The following is a description of a gene set: The pathogenesis of incipient Alzheimer's disease (AD) has been resistant to analysis because of the complexity of AD and the overlap of its early-stage markers with normal aging. Gene microarrays provide new tools for addressing complexity because they allow overviews of the simultaneous activity of multiple cellular pathways. However, microarray data interpretation is often hindered by low statistical power, high false positives or false negatives, and by uncertain relevance to functional endpoints. Here, we analyzed hippocampal gene expression of nine control and 22 AD subjects of varying severity on 31 separate microarrays. We then tested the correlation of each gene's expression with MiniMental Status Examination (MMSE) and neurofibrillary tangle (NFT) scores across all 31 subjects regardless of diagnosis. These well powered tests revealed a major transcriptional response comprising thousands of genes significantly correlated with AD markers. Several hundred of these genes were also correlated with AD markers across only control and incipient AD subjects (MMSE > 20). Biological process categories associated with incipient AD-correlated genes were identified statistically (ease program) and revealed up-regulation of many transcription factor/signaling genes regulating proliferation and differentiation, including tumor suppressors, oligodendrocyte growth factors, and protein kinase A modulators. In addition, up-regulation of adhesion, apoptosis, lipid metabolism, and initial inflammation processes occurred, and down-regulation of protein folding/metabolism/transport and some energy metabolism and signaling pathways took place. These findings suggest a new model of AD pathogenesis in which a genomically orchestrated up-regulation of tumor suppressor-mediated differentiation and involution processes induces the spread of pathology along myelinated axons. Human Gene Set: BLALOCK_ALZHEIMERS_DISEASE_DN from publication Blalock EM, Geddes JW, Chen KC, Porter NM, Markesbery WR, Landfield PW (PMID 14769913) Genes down-regulated in brain from patients with Alzheimer's disease. species: Homo sapiens, and this is the list of marker genes: CNKSR2, PGK1, TAF9, SNRK, MMD, SCN3B, BECN1, COX4I1, ATP1A2, CYCS, UQCRQ, FUCA1 (alpha-L-fucosidase 1), ADH5, STAMBP, PFN2 (NCBI Gene Id 85837), MCM4, DUSP6, PITPNB, SLC4A3, TSPAN3, ATP5MG, AUH (NCBI Gene Id 549), RPL6, STS, SRSF5, PAK3, SSBP1, UQCRC1, NDUFA7, P4HA1, RTN1, BLZF1, CDK7, USP9Y, FSD1, HDGFL3, TSPOAP1, LRP1B, UQCC1, MAP4K3, KHDRBS1, DDX1, MAN1A1, SSR1, NDUFB2, HYOU1, SPINT2, PTN, LETMD1, CDO1, EPHA4, NELL1, ADORA2B, KCND2, RPRM, STMN3, GPM6A, POLR2J4, TIMM23, PGRMC1, PEX19, CCNL1, HADH, TBPL1, GNAL, BRINP1, PGAM1, PEG3, APLP2, ATRX, PTPRT, TUBB2A, KIT, RPL14, SLC25A3 (NCBI Gene Id 5250), RIDA, NEFL, TMSB10, CLASP2, SLC9A6, FH, ADK, FAM106A, ATP5IF1, UCHL3, TM2D3, YME1L1, RHEBP1, CAB39, USP10, PSPC1, CDKN2D, SNX10, SST, SUMO1, HNRNPK, HSD17B12, ATP5F1A, FCER1G, SEPTIN6, WDR12, PIP5K1C (NCBI Gene Id 23396), PCMT1, ITPKA, GAA, TRIB1, MTMR9, ALDOC, RGS7, SLC6A1, MEF2C, HSPA9, HPCA, REEP5, PON2, MEF2A, KL, HSPD1, SSB, TTC3, CHP1, PSMB3, POLR2K, NEUROD6, TAC1, RASA4, USO1, VIP, ME3, SNAPC5 (NCBI Gene Id 10302), TERF2IP, DDOST (NCBI Gene Id 1650), HSPA14 (NCBI Gene Id 51182), SNX4, SYT5, NME1, SOCS2, PTX3, RPL35A, NIPSNAP2, CCK, YWHAB, HLTF, PRKCB, NDUFA2, PTGES2, GUCY1B1, OMG, TCEAL1, FABP7, B4GALNT1, GNAO1 (G protein subunit alpha o1), DDN, COX6B1, FN1, IFIT1, YWHAZ, TMED2, MED6, PDHB, SDHA, ATP6V1F, GLS, PRKAR1A, EXOC1, NDUFAB1, ARPC3, SCP2, BCAS2, CRIM1, KIF5C, BTN2A1, MTCH2, NPY, DRAP1, MGLL, TSNAX, PSMD10, FCGR1A, FBXL2, GOT2, SLC25A12, CDC27, GET3, WBP4, RPP30, PSMA7, ATP6V0C, PSMG2, UGGT2, MAP2K4, POP7, PSMA5, FHIT, SELENOT, DYNC2LI1 (dynein cytoplasmic 2 light intermediate chain 1), TMEM126B, ENOPH1, GCH1, SYNGR1, CRYZ, MICU1, NDUFS2, ATP5MC3, HINT1, NEUROD1, DGUOK, HTR2A, VDAC3, GASK1B, SLC25A14, CSNK1G3, DENND4A, ZW10, PEX3, PGM1, HPRT1, DARS1, AXL, USP15, TMEM14A, LSM3, ARPP19, SLC35A1, SELENOF, MACROH2A1, MLF2, YPEL5, PIP5K1B (NCBI Gene Id 8395), ACHE, NDFIP1, MXD1, FLRT2, RNF6, RBBP7, KCNN2, FXYD6, ORC3, TUFM, ITPR1 (inositol 1,4,5-trisphosphate receptor type 1), STMN2, ASMTL, APC, GAPDH, DIMT1, EIF2B1, PSME3, KPNA3, PTH2R, IPO7, RCOR1, METTL5, PFDN1, CCT3, HCCS, RPL38, NUDT11, SUPT4H1, DNAJC12, BET1, GPR22, GHITM, TUBB4B, CAPNS1, ADGRL3, ARPC1A (actin related protein 2/3 complex subunit 1A), ISCU, SCN3A, NUP153, SERPINI1, ATP6V1D, CKMT1B, SERGEF, LAMTOR5, SLC25A11, CACNB2, CDK16, TCERG1, MFN1 (NCBI Gene Id 55669), ZNF706, NMNAT2, CLDN10, B3GALT2, WASHC3, TASP1, BEX3, RFC5, MGA, SAT1, ANO3, PSMD12, ABHD14A (abhydrolase domain containing 14A), CKS2, UQCRC2, NPTN, DYNC1I2, ACO2, ZC3H15, RIT2, COX5B, SCHIP1, SYNCRIP, SIRT3, GET1, KIF1B, UBE2N, SRSF3, ZMYM4, ATP6V1H, TLE5, C6orf120, SEC31A, SYN2, SAP18, ATP2A2, FAM216A, SUMO2, EIF5, HSPA5, DYNC1I1, NRIP1, TSPAN13, PCCA, GLT8D1, ANK3, CAMK2A, NAE1, PKNOX2, SNCA, GLUD1, CDK5R1, PLK2, TARBP1, GLO1, C1orf21, CSNK2A1, CAP2, SULT4A1, PRAF2 (NCBI Gene Id 11230), TSPYL1, GRIA3, SNRPD2, MPV17, COX8A, RGS2, NDUFB3, APP, GPC5, DYNLL1, COX6C, CABP1, AP3S1, GALC, ECT2, LTN1, NNAT, AK5, HPCAL4, MAOA, HSPH1, DNAJA1, ANOS1, SEC13, HOPX, TLK1, ARF5, ETFA, NRSN2 (neurensin 2), ARL1, CDH8, SCN2A, PNMA2, YIPF3, NDUFS4, VCP (valosin containing protein), CNNM1, TOMM20, IFT25, AP2B1, ZNF204P, TRIM36, GRIN2A, HEXB, RGS20 (regulator of G protein signaling 20), ITSN2, MECR, OGT, NDUFA8, STX1A, NRGN, NUFIP1, HMGN4, ADAM23, DMTN, PSMB5, DYNLRB1, CALM1, LRPPRC, NPAS2, HSPE1, DYNC1LI1, GLRB, NREP, MCTS1, RAPGEFL1, SUCLA2, SNU13, CDK17, RAB6A, ENY2, CNR1, SRP54, USP14, RTL8A, HBA1, MRPL22, UCHL1, SNN, DDX5, AMFR, UAP1, CAP1, ARF1, SLIT2, ARL4C, LGALS8, PLCL2, TTC1, DIPK1A, C17orf75, CYP26B1, SRPRA, ZNF75D (zinc finger protein 75D), ATP5PB, RECQL, CDS2, PINK1, COPS5, PSMD6, MATR3, CSE1L, SLC25A6, CEPT1, PDS5B, CTNNA2, THYN1, GADD45GIP1, COMMD3, RCHY1 (NCBI Gene Id 29027), GSTM3, DCTN6, RFX5, PTPRR, EPCAM, DYNLT3, PRDX4, ACTR1B, SHANK2, REEP2, CPSF6 (cleavage and polyadenylation specific factor 6), CS, SMYD2, ALOX5AP, RUNDC3A, CALM3, PI4KA, TACC2, SPG21, ARHGEF4, ARCN1, PSMB2, AASDHPPT, WBP11, DNAJC8, RBX1, KALRN, MAPK8IP1, CLIC2, ADCY2, TIMM17A, POLR2B, RTN3, TRMT11, DGKB, CUTA, SORBS2, CEP15, MTF2, PIGP, PDE4DIP, PTDSS1, CCNG2, PTGER4, AP2M1, MAP1A, RPL15, ATR (NCBI Gene Id 57307), SNRPA1, AHSA1, FAIM2, PRKAR2B, ETS2, PJA1, SEZ6L, GABRB3, TBK1, ANAPC13, SHANK1, PHTF1, UBXN4, OGA, AP2S1, NME2, IARS1, GNG3, UQCR11 (ubiquinol-cytochrome c reductase, complex III subunit XI), GAD2, CAMKK2, GUK1, NCBP2, LRRC8B, TFDP1, SFPQ, NELL2, DHCR7 (7-dehydrocholesterol reductase), ACAT1, COA3, CASP8AP2, ADGRB2, ARF3, EPHB2, KCNIP1, VEGFA, ATXN10, HSPA4L, KIDINS220, PPP3CA, RB1CC1, TMEM50A, ATP6AP1, XK, SCFD1, GTF2A2, NDUFB11, SLC1A4, NEDD8, PIAS1, RAB11A, UXS1, JPH3, DCAF6, FABP3, PPP2CA, HERC2, PFKM, MRPL13, PPP3R1, EEF1E1, BCL7B, USP9X, MGST3, ATP6V1G2, HNRNPD, GAP43, GPI, XPO7, CCT2, SON, BSG, S1PR1, VSNL1, DIO2, AKAP11, ARHGEF9, TRO, EIF2S1, KIF3C, PRDX3, UBC, PCNT, YWHAH, PTPRN2, COPS4, HTRA2, RSU1, PAPSS1, LSM5 (LSM5 homolog, U6 small nuclear RNA and mRNA degradation associated), HTR1E, TOP1, COX7C, MRPS15, ACTR10, UBE2M, AKTIP, SKAP2, AKAP12, PDCD2, DCTN2, SEC61A2, SHC3, SCRG1, RNF11, FBXO3, ATP2B2, MOCS2, VMP1, PPP2R5E, CKB, ARFGEF2, THY1, DDX47, PPP1R11, COPA, GSTO1, CCPG1, ATP6V1C1, NDUFB5, SRP19, ELMO1, EIF3D, OXCT1, KCNAB2, TDP2, RAB3A (RAB3A, member RAS oncogene family), HNRNPC, PRKCI, SV2A, P4HTM, GSPT2 (NCBI Gene Id 83029), ATRN, NFYC, FKBP3, ENO2, G3BP2, SCG5, ENSA, SAMM50, RFPL1S, CACYBP, GRPEL1 (GrpE like 1, mitochondrial), TXN, CDC40, IMP4, RTN2, NEFH, LMO4, ATP1B1, CNPY2, MRPL3, MOXD1, HLA-G, CXCL14, SMARCA2, NIF3L1, RDH11, GNB1, ARIH2, ATP8A2, PTGES3, COX7A2L, OXR1, SC5D (NCBI Gene Id 6309), NEFM, NECAP1, BBLN, UBL5, ATP6AP2, IPO5, FBXO21, ZNF184, CHN1, NF2, PCNA (NCBI Gene Id 5111), SCG3, PSMD11, MED17, UBE2V1, ATP2B1 (NCBI Gene Id 490), ABAT, FRG1CP, HIGD1A, STXBP1, TIGAR, DDT, TMEM147, HERC1, PITRM1, SCAPER, AP3B2, DIRAS2, VPS41, FECH, NCAN, STK24, WIF1, WASF1, RABEPK, MYL12B, SRP72, PTS (6-pyruvoyltetrahydropterin synthase), RASAL1, COX7A2, ACOT2, AGAP2, RRAGA, TRIM32, SPCS1, NDUFA4, SEM1, LDOC1 (LDOC1 regulator of NFKB signaling), EID1, DLGAP1, CD59, EPS15, FARS2, CYC1 (NCBI Gene Id 1537), JAK2, LANCL1, ERGIC2, R3HDM1, ZNF207 (zinc finger protein 207), IFNGR2, ST6GALNAC5, ARPC5, PTRH2, CCDC92, BSN, UTP18, TACO1, OAT, PPP2R5C, FOXG1, PCDHA9, GABBR2, ASIC2, NRXN1, PSMD1, SRD5A1, HS3ST2, NAP1L2, IGF1, TMBIM6, BCAP29, MSH2, HSP90AA1, GABBR1, UTP25, ATP5F1E, VAMP1, PEX7 (peroxisomal biogenesis factor 7), DZIP1, MYT1L, GGCX, CHGA, SYN1, ATP5MF, NIPSNAP1 (nipsnap homolog 1), DNAJC6, SLC1A1, RANBP9, SUB1, UQCR10, CCND2, DEGS1, COL5A2, MAPRE3, NQO1, PALM2AKAP2, MKKS, GORASP2, ENC1, PLCB1, DIRAS3, ASH2L, QPCT (NCBI Gene Id 25797), BEX1, PPT1, WDR7, NSFL1C (NCBI Gene Id 55968), ELMO2, MAPK9, SACS, GNAS, UBE2G1, PDHX, TOMM70, MDH2, RPS26, CA11, CCN3, COX6A1, PPP1R12A, ESD, NT5E, UROS, TFRC, ACTR1A, ENTPD3, NDEL1, ORC5, CDH11, PFDN2, KPNA2, LRRN3, PRPF19, FGF13 (fibroblast growth factor 13), ABHD6 (NCBI Gene Id 96026), NETO2, AZIN1, IDS, ATP6V1A (ATPase H+ transporting V1 subunit A), VARS1, ELOVL4 (NCBI Gene Id 94678), MRPL57, HSPA13, NRN1, ADCY9, MAP2K1, OLFM1, ATP5F1B, ANXA7, VAMP2, USP6, SDHD, NDUFC2, ATXN1, PRPS1, COX7B, STAT1, RFPL3S, CDH18, METAP1 (NCBI Gene Id 23173), RIPOR2, L1CAM, CLIP3, SNTG1, CISD1, SCAMP1, SLC35B1, DMXL2, KPNB1, CRNKL1, ABCB1, OAZ2, NFU1, POLR2G, PCDH11X, SRPK2, APEX1, BCL11A, DMD, RPL31, TMEFF1, NIT2, ACTR2, PENK, SDHB, UBE2B, MFF, INA (NCBI Gene Id 9118), CUL1, PSMB6, RPE, UGP2 (UDP-glucose pyrophosphorylase 2), PDCD5, TPI1, STXBP5L, DUSP5, RTL8C, NDUFV2, UBE2E3 (ubiquitin conjugating enzyme E2 E3), ADI1, BAG6, MCCC2, LHX2, RIMS2, DOCK3, MAGEL2, RUSC1, DSC2, WFDC1, ADGRB3, ME1, RUNX1T1, FAM162A, ABCC4, ATIC, EDN3, FXYD7, PANX1, ASPH, NPEPPS, PSMB4, CDH10, CAND1, KIF2A, PANK4, PCDH7, GOT1, PDE2A, BCAN, ELAVL4, MPPED1, LAMTOR3 (NCBI Gene Id 8649), DLD, MAPK1, MLLT11, PFDN4, ATP5F1C, ARHGEF3, TM2D1, COX11, GRIA2, RNF5, RAB7A, TMOD1, TCEAL2, ACOT13, DEAF1, H2AZ2, MRPL15, EIF3K, NDUFA10, ARPC5L, RALB, CDK14, ALDH2, PCP4, MAGED1, MAPK14, F8A1, CCT4, KCNJ3, SH3BGRL, UBL3, B2M, BABAM2, BNIP3L, OPA1, B4GALT6, ACYP2 (acylphosphatase 2, NCBI Gene Id 98), PDE4B, HMG20A, TAGLN3, KATNB1, APBA2, SV2B, ITM2B, CRH, RAD23B, ACTR3, EIF6, RAD51C, GLOD4, PTK2B, CHL1, MTX2, SEC23B, VAMP7, PDIA6, SYNJ1, FIBP, PREP, PAFAH1B1, PIGK, RAPGEF4, ROCK2, BHLHE40, MRPL20, CDK5, TSPAN7 (NCBI Gene Id 7102), MRPS28, NARS1, GRIA1 (glutamate ionotropic receptor AMPA type subunit 1), ACSL3, PPIA, MOB4, UQCRH, RAB2A, NDUFB8, OSBPL10, GOLGA8A, KLC1, HSF2, SERINC3, PCLO, GNA14, MPP1, VBP1, RGS4, LSM4 (LSM4 homolog, U6 small nuclear RNA and mRNA degradation associated), ITGB1BP1, ATP5MJ, GLUL, PREPL, ATP5PF, PSMD14, DLG2, ATP5PD, SNRNP27, DNAJB9, PRDX2 (NCBI Gene Id 7001), PDE4D, ELOVL2, PRKAR1B, ULK2, EBP, DLGAP2, ASF1A, KDELR2, DLAT, CHCHD2, ZNF142, LAPTM4B, HLA-B, CHRDL1, CPNE6, VPS33B, KIFBP, WDHD1, SLC12A5, SYT1, ASTN1, CCNA1, PMPCB, ARMCX1, SLC25A5, TXNDC9, RNF38, ECH1, RBMX, PITPNA, SUPT7L, PEX1, MEG3, MTMR1, LDB2, KCNQ2, ACTL6B, CDC42, SLCO1C1, MYL12A, RNF14, IFRD1, ATP13A2, C11orf58, ADIPOR1, CRYM, SCCPDH, PCSK1 (proprotein convertase subtilisin/kexin type 1), PSAT1 (NCBI Gene Id 29968), STOML1, PDHA1, FAM32A (NCBI Gene Id 26017), TNFRSF21, USP33, MEMO1, GMPR2, LRP8, BNIP3, ROBO1, TPD52L1, ZNHIT3, PEG10, PAM, AMY1A, SLC30A9, CHMP2A (charged multivesicular body protein 2A), SMAP1, ADAM17, SKIC8, TMEM208, MRPL16, CCDC6, ATP6V1E1, MRPS10, SH3YL1, HSP90AB1, NNT, SH3GLB2, KCNK1, LAMTOR2, TRPC1, PTEN, FKBP1B, MRPL19, VDAC1, NDUFB4, ZMAT3, PPP2R2B, RXYLT1, KCNF1 (potassium voltage-gated channel modifier subfamily F member 1), TM6SF1, PCCB, GOLT1B, ARF4, PUM2, PSD3, TENM1, LXN, GSTA4, RTN4, DNM1L, HEY1, NDUFA3 (NCBI Gene Id 4696), SNX3, SEC23IP, RNMT, ASAH1 (NCBI Gene Id 79795), LRP12, PSMC2, NOLC1, CACNG3, EFNB2, RCN2, UBE2A, NR2C1, PAIP1, EIF1B, LZTS1 (leucine zipper tumor suppressor 1), EIF2B3, COPS7A, TOR1A, PAK6, CLTC, PGS1, SNAP25, MOAP1, CUL2, SNRPN, ARNT2, BCL11B, HNRNPDL (heterogeneous nuclear ribonucleoprotein D like), COX5A, USP25, LARGE1, STAM, NOS1AP, ACP1, IDH3B, SLC25A32, F8, GPAA1, RPN2, RCAN2, KIFAP3, ADGRL2, EIF2AK1, ATP5PO (ATP synthase peripheral stalk subunit OSCP), PPA1, CRMP1, FHL1, NDUFB1, UBP1, ALG8, KCNAB1, GLRX, ACOT7, THOC5, SRSF2, RNASET2, TOX3, PNN, MET, ACTN1, COL4A1, RPS21, PSMG1, CAMK1G, EPHA7, ABCE1, SYNGR3, CD200, PPP1R2, CNOT7, TUBG2, USE1, GABRA2, DYNC1H1, TSG101 (tumor susceptibility 101), AP4S1, HBB, VLDLR, CASD1, CDC5L, ILF3, ACAD8, BAG5, PTPRE, TRRAP, NDRG4, HNRNPR, PSMA1, PPID, MTHFD1, PIK3R4, ZFR, PPP3CB, SCN1A, MDH1, CNTNAP2, MCCC1, PPP1R7, PCSK2, TRIM37, MARS1, FBXW7, SNCG, MRPL18, VWF, UBE2D3, ACTR3B, HSPA8, RANBP2, TOX, RAP1GDS1, TPGS2, TPBG, BSCL2, PARP1, ARPC2, MNDA, RGS14, NAA35, CSPG5, FERMT2, PRMT1, UBA3, NUMB, COPS8, FGFR3, CCT5, NDUFA5, ATP2C1, ALDH5A1, PEX11B, NDUFS3, MTERF3, CLIP1, CCZ1, PSMC6, TBCA, CCNH, MATK, LDHA, GAD1, MTMR4, SORCS3